The following is a description of a gene set: Abnormal uvula morphology Abnormality of the uvula, the conic projection from the posterior edge of the middle of the soft palate. Human Gene Set: HP_ABNORMAL_UVULA_MORPHOLOGY species: Homo sapiens, and this is the list of marker genes: POMK, PIGW, SPTBN1, STAC3, B4GAT1, CUL3, FANCB, KIF14, PIGL, SATB2, PALB2, DDX3X, FANCL, BRCA1, FBXO11, GJA8, SLC39A13, CDH11 (cadherin 11), ORC1, BRIP1, GLI2, SPEG, PIGO, B4GALT7, SMAD4, EIF4A3, SLX4, KCNK9, TCTN3, ALG3, RPS28, STAG2 (NCBI Gene Id 10735), EFEMP1, SON, TBX1 (NCBI Gene Id 7413), IPO8, RTL1, KDM6A (NCBI Gene Id 7403), DLK1, HYLS1, FKTN, TGFBR1 (NCBI Gene Id 7046), RNU4ATAC, ASPH, SMARCD1, DHCR7, POGZ, CDT1, NODAL, UBE2T, XRCC2, IFT140, PGAP3, BRCA2, WDR35, TTN, COL4A1, KIF7, KAT6B, HAAO, KMT2C, SUPT16H, ZEB2, FGF10, KMT2D, TXNL4A, FANCG, PLCH1, B9D2, ERCC4, LARGE1, CDC6 (cell division cycle 6), COL2A1, ATP6V1B2, CRIPTO, ORC6, KDM6B, BCOR, POMT1, PTCH1, PRR12, TP63, NXN, PIGV, ORC4, FGFR3, KCNH1 (potassium voltage-gated channel subfamily H member 1), BGN, ALG9, DLL1, B3GALNT2, SMCHD1, CRPPA, TGDS, PGAP2, PIEZO2, SEPTIN9, RAD51, RPS23, STIL, MYL11, DLG3, SIAH1, METTL23, FANCD2, XYLT1, TGFB3, HNRNPK, TBCE, MAP3K7, DISP1, FANCF (FA complementation group F), MAD2L2 (mitotic arrest deficient 2 like 2), FGFR1, ROR2, COL11A2, EDN1, INTS11, GNAI3, DHCR24, FANCM, FANCI, SMPD4, RNU4-2, SKIC3, IRF6, PPP1CB, FGFR2, TWIST1, FANCC, CDON, PI4KA, MEG3, FOXH1, EYA1, SELENOI, SMS, TGFBR2, GMNN, HYAL1, SMAD3, UBB, DVL1, KCNN3, GJA5 (NCBI Gene Id 2702), ZIC2, FANCA, SHH, SERPING1, COL11A1, SHMT2, SMAD2, AMMECR1, ARMC9, RFX7 (regulatory factor X7), CHD4, SIX3, USP9X, RYR1, PGM1, SETD5, POMGNT1, DDX59, POLA1, CDC45, PLCB4, TGFB2, AMER1, KCTD1, AEBP1, BMP4, PIGY, DAG1, SMC1A, RFWD3, POMGNT2, POMT2, FOXI3, SIX1, RXYLT1 (ribitol xylosyltransferase 1), FGF8, RPL5, BIN1, RECQL4, FANCE, SEC23A, FILIP1, FTO, FLNA, GLI3 (GLI family zinc finger 3), FKRP, SNRPN, SLC2A10, TGIF1, RAD51C, PTDSS1, PGAP1, IGBP1, GAS1, TBX22, GRHL3